The following is a description of a gene set: Genes containing one or more binding sites for (Phc1) in their promoter regions (TSS -1000,+100 bp) as identified by GTRD version 20.06 ChIP-seq harmonization. from publication Yevshin I, Sharipov R, Kolmykov S, Kondrakhin Y, Kolpakov F (PMID 30445619) Mouse Gene Set: PHC1_TARGET_GENES species: Mus musculus, and this is the list of marker genes: Prox1, Lhx5as1, Otx2os1, Lhx6, Hmx2, Tmem115, Six3os1 (NCBI Gene Id 77868), Hoxc8, Tmem132e, Smarca2, Fev, 2610016A17Rik, Meis2, Pitx2, Hoxa11os (homeobox A11, opposite strand), Otx1, Zmiz1 (zinc finger, MIZ-type containing 1), Pitx1, Gata3un, Klhl14, Gm26973, Helt, Zic4, Lmx1b, Tal1, Six3, Sgpl1, Lhx1os, 9130024F11Rik, Nr2e1, Pcdh10, Hand2os1, Irx3os, Ebf3 (NCBI Gene Id 73115), Barx2, Bmi1, Pax2, Hoxd11, 2610316D01Rik, Hoxa11 (homeobox A11), Lbx1, C130021I20Rik, Foxb2, Gm13261, Hoxb3os, BC006965, Prdm6, Fgfr3, Wnt7b, Tfap2a, Nkx2-1, Hnf1b, Fat4, Dmrt2, Mir615, Hand2, Pcdh7, B230323A14Rik, Lhx2, Egr3, Wnt5a, 9430015G10Rik, Prox1os